Given this list of marker genes Psmb8, Stard3, Tcstv4, Rasa4, Dennd1b, Cd300lf, Ifit1, Ifi208, Ly6c2, Tapbp, Nmi, Lpxn, Casp4, Oas3, Zyx, Tspo, Ifi204, Lgals3bp, Tfec, Snx2, Mlkl (NCBI Gene Id 74568), Trim30c, Dhx58, Ifitm6, Irf7, Tent4a, Ifi213, Mov10, Myd88, Vps37b, Pml, Rbms1, Apobec3, Ogfr, Dop1b, Bst2, Ubc, Psma5 (NCBI Gene Id 26442), Rtp4, Parp12 (poly (ADP-ribose) polymerase family, member 12), Pttg1, Phf11b (NCBI Gene Id 236451), Hspa5, Plac8, Ifi205, Ppp1r2, Il18, Pnp, Oasl2, Dnaja1, Slfn9, Vcan, Ifi35, Sppl2a, Cited2 (NCBI Gene Id 17684), Lgals9, Ifi209, Srsf7, Znhit1, Txn1, Usp18, Rnpep, Gbp7, Ncoa7, Ethe1, Ass1, Scimp, Ctsc, Svbp, Irgm1, Cxcl10, Ifi207, Ms4a6c, Uba7, Pfkp, Dbnl, Ppa1, Azi2, Prdx6, Cldnd1, Sp100, Akt3, Fcgr1, Tmbim6, Magohb, Ehd4, Trim12c, Xaf1, Cfb, Tap2, Mitd1, H2-T23, Lamp2, Ifi206, Ccl12, Mpeg1, Cycs, Tmsb10, Tmem219, Ms4a6b, Phf11a, Epsti1, Mxd1, Plod3, Tle3, Stxbp3, Ms4a4c, Slc25a22, Samd9l, Xrn2, Fam111a, Sp110, Gbp5, Camk2d, Evl (NCBI Gene Id 14026), Daxx, Gch1, Il15, Parp14, Ranbp2, Aldh1b1, Fam241a, Jpt1, H2-T22, Sp140, Ifit1bl1, Mpp1 (NCBI Gene Id 17524), Gpr141, Stat2, Fndc3a, Xdh, Tap1, Igtp, Dtx3l, Isg15, Hdac1, Ifitm3, Sgcb, Ccdc25, Gbp9, Slpi, Trafd1, BC005537, Irgm2, Slfn2, Prkx, Npc2, Ifi203, Dnaja2, Gramd2b, Bbx, Mbd2, Gbp2, Rin2, Slc25a12, Arf4, Tdrd7, Zbp1, Rnasel (NCBI Gene Id 353203), Trim30b, Sdc3, Sell (NCBI Gene Id 98392), Helz2, Sdcbp, Cd69, Iigp1, Dek, Morf4l2, Ms4a6d, Naa25 (NCBI Gene Id 71630), Grn, Selenow, Nampt, Hmox2, Msrb1, Ifit3b, Ly6e, Psmb3, Prpf38a, Gbp3, Rnf213 (NCBI Gene Id 672511), Slc15a3, Znfx1, Tor1aip1, Cmpk2 (cytidine/uridine monophosphate kinase 2), Clec2d, Tmem184b, Atp11b, Macroh2a1, Ddx60, Chmp4b, Zup1, Psmb10, Mndal, Asb13, Herc6, Isg20, Calhm6, Max, Ifit3, Psmb9, Trim34a, Serpina3g, Nt5c3, Glrx (glutaredoxin), Ifit2, Tbc1d1, Fgl2, Cd40, Rilpl1, Klrk1, Ly86, Vrk1, Ccr1, Casp1, Slfn5, Slfn8, Ifi47, Casp3, Srsf3, Marchf5, Actr3, Stat1, Rsad2, Trim30a, Nes, Stx11, Tor3a (NCBI Gene Id 30935), Atp6v1b2, Phf11d, Ifi211, Dnajc15, 9930111J21Rik2, Socs1, Capza2 (capping actin protein of muscle Z-line subunit alpha 2), Vapa, Rigi, Pkib, Ube2l6, Oasl1, Oas1a, Mx1, Usp25, Tor1aip2, Slfn1, Slfn4, C1galt1c1, Tpm4, Ccl2, Cd164, Casp8, Psme1, Samhd1, Eif2ak2, Sumo1, Ifih1, Dck, here is a description of the gene set: species: Mus musculus Genes positively differentially expressed in cell type: Monocyte upon treatment with cytokine: IFN-β in mouse lymph nodes in vivo. from publication Cui A, Huang T, Li S, Ma A, Pérez JL, Sander C, Keskin DB, Wu CJ, Fraenkel E, Hacohen N (PMID 38057668) Cytokines mediate cell-cell communication in the immune system and represent important therapeutic targets. A myriad of studies have highlighted their central role in immune function, yet we lack a global view of the cellular responses of each immune cell type to each cytokine. To address this gap, the authors created the Immune Dictionary, a compendium of single-cell transcriptomic profiles of more than 17 immune cell types in response to each of 86 cytokines (>1,400 cytokine-cell type combinations) in mouse lymph nodes in vivo. A cytokine-centric view of the dictionary revealed that most cytokines induce highly cell-type-specific responses. For example, the inflammatory cytokine interleukin-1β induces distinct gene programmes in almost every cell type. A cell-type-centric view of the dictionary identified more than 66 cytokine-driven cellular polarization states across immune cell types, including previously uncharacterized states such as an interleukin-18-induced polyfunctional natural killer cell state. Mouse Gene Set: CUI_MONOCYTE_IFNB_RESPONSE_UP